Given this list of marker genes Braf, Id2, Cdh4, Cd40lg, Pbrm1 (NCBI Gene Id 76748), Fmr1, Tox, Ace, Dcstamp, Ptk2, Cul7, Vsir, Stk25, Mtor, Lmod3, Cdkl5, Nlrp3, Tiam2, Ctf2, Cdkl3, Il15, Smarcd1, Sgk1, Ascl1, Fbxo31, Nrp1, Islr2, Wls (NCBI Gene Id 99763), Ilk, Il6, Cftr, Sox13, Sart1, Sox4, Ccr1, Ctnnb1 (catenin beta 1, NCBI Gene Id 12387), Nkx6-1, Zfyve27, Dixdc1, Xrcc6, Disc1, Dhx36, H2-Ea, Igf1, Pax6, Sox11, Ell3, Pak3, Il10 (interleukin 10), Bhlhb9, Serpinf1, Mfn2, Wnt5a, Il2, Olig2, Smarca4, Rnd2, Itpkb, Il4, Atp11c, Ror2, Ntrk2, Slc9b2, Ist1, Ss18l1, Mir124a-1, Slc7a5, Aurka, Eif2b2, Ap3b1, Stk11, Evi2, Mmp14, Myb, Clec7a, Mir124a-2, Rtn4, Ntn1, Mpl, Lig4, Nr2e1, Fos, Kdm1a, Ptpra, Chodl, Anapc2, Trf, Cyp51, Actb, Cip2a, Gfap, Tgfb1, Amigo1, Mup20, Fgf2, Ccl19, Pou4f1, Smurf1 (SMAD specific E3 ubiquitin protein ligase 1), Rhoa, Grip2, Fxn, Rb1 (NCBI Gene Id 19645), Nrdc, Myod1, Cd83, Dbnl, Nrg1, Il7r, Cd1d1, Dbn1, Zbtb7b, Actl6b, Ufl1, Cx3cr1, Gas6, Proc, Synj1, Tnfrsf11a, Trem2, Rassf10 (NCBI Gene Id 78748), Stat5b, Actn3, Irf1, Smarcd3, Otp, Ccl9, Fbxw8, Pak1, Car2, Plxnb2, Ppp3ca, Nkx2-2os, Il20, Jade2, Ptn, Vnn1, Kalrn, Actr3, Carmil2, Cux2, Pcid2, Lrp8, Snap91, Bmp4, Sox2, Gimap3, Ptprd, Limk1, Rara, Itpka (NCBI Gene Id 228550), Srrt (serrate RNA effector molecule homolog (Arabidopsis)), Map3k13 (mitogen-activated protein kinase kinase kinase 13), Snw1 (SNW domain containing 1), Xrcc2, Gja1, Nckap1l, Ppargc1b, Aspa, Il3, Pparg, Il1rl2, Bcl11a, Dlk1 (NCBI Gene Id 13386), Plxnb3, Clcn2, Inpp5d (inositol polyphosphate-5-phosphatase D), Mdk, Hdac2, Mag, S1pr2, Dicer1, Tle6, Tnfsf4, Evi2b (ecotropic viral integration site 2b), Map2k2, Twf2, Sox10, Nkap, Neurl1a, L1cam, Bcl2, Zbtb46, Tespa1, Spen (NCBI Gene Id 56381), Hsp90aa1, Il2ra (NCBI Gene Id 16184), Ccr2, Cask, Wnt2, Acin1, Tescl, Hif1a (NCBI Gene Id 15251), Ninj1, Smarcd2, Plxnb1 (NCBI Gene Id 70220), Shh, Zfp36l1 (zinc finger protein 36, C3H type-like 1), Ephb2, Zmiz1, Bex1, Slc30a1, Gjc2, Tbc1d24, Cd4, Gdi1, Ptprc, Creb1, Rhoh, Lilrb4b, Prkci, Smarcc2, Hdac1 (NCBI Gene Id 630524), Map1b, Vegfa, Fzd3, Faim, Egr2, Zbtb1, Cdh5, Ddrgk1, Shank3, Hap1, Map2k1, Ankrd27, Golga4, Ager (NCBI Gene Id 11596), Trp73, Smarce1, Ccr7 (NCBI Gene Id 12775), Jun, Ikzf1, Reln, Nin, Clcf1, Metrn, Brd2 (bromodomain containing 2), Tmem64, Ngf, Klhl25, Pck1, Etv5, Dnm1l, Pou4f2, Il4ra, Kit, Gimap5, Wdr62, Plxnc1, Dscam, Actl6a, Rela, Lilrb4a, Pla2g3 (NCBI Gene Id 237625), Smad7, Tiam1, Zfp488, Star, Il17a, Socs1, Rufy3, Qki, Grip1, Spint1, Ccl3, Arid2, Dcx, Il12a, Stat5a (NCBI Gene Id 20850), Mecp2 (methyl CpG binding protein 2), Nap1l1, Pnp, Add1, Baiap2, Abcb1a, Ppp1cc, Tnfrsf12a, Myf5, Fxr1, Il18, Wnt3, Rnf112, Anxa1, Serpine2, Asxl2, Grm5, Prpf19 (pre-mRNA processing factor 19), Nkx6-2, Mapk8 (mitogen-activated protein kinase 8), Nedd9, Gfi1b, F11r, Vegfc, Gsk3b, Mir219a-2, Pias2, Ccr1l1, Marcks, Nptn, Foxg1, Tlr9, Lyn, Il5, Arid1a, Skint1, Malt1, Hes1, Sema7a (NCBI Gene Id 78407), Pik3r6, Xlr3b, Runx3, Cldn5, Brd4, Bin1, Hoxd11, Parp6, Zap70, Man2a1, Dmrta2, Prl2c2, Adcy10, Crabp2, Ndel1, Lta, Cyfip1, Wnt3a, Egr3, Tgfbr2, Foxo3, Nfkbid, Shb (src homology 2 domain-containing transforming protein B), Cbfb, Arrb2, Mir219a-1, Adipoq, Hdac6, Smarcc1, Bmp2, Il23a, Picalm, Ep300, Mfn1, Arhgap32, Akap5, Syk, Hcls1, Cd74, Trpc5, E2f1, Myf6, Gata3, Tspo, Nfkbiz, Hsf1, Eeig1, Lpar3 (NCBI Gene Id 65086), Prmt5, Brd7, Plag1, Eef2k (eukaryotic elongation factor-2 kinase), Smarcb1, Camk2b, Axl (AXL receptor tyrosine kinase), Lgals9, Numb, Adam8, Xbp1, Numbl, Ihh, Shtn1, Ptprz1, Ifng, Flt1, Nog, Myc, Egfr, Mme, Kdr, Caprin2, Sh3glb1, Fxr2, Ada, Sox12, Smo, Rgs14, Zfp335, Phf10, Cx3cl1, Foxp3, Xrcc4, Lif, Cd27, Nkx2-2, Klf10, Rptor, Cdon, Oprm1, Zfp609, Bnc1, Fzd4, Bmpr2, Epha4, Afdn, Tlr2, Tnfsf9, Apoe, Hmgb1, Il36b, Il4i1, Spi1, Mir326, Il1b, Aspm, Fadd, Prkdc, Caprin1, Gli3, Flt3l, Tnfrsf1b, Kitl, Robo1, Dag1, Trim32, Myo5b, Hax1, Bad, Atxn1, Gpr68, Fes, Csf1, Itgb1, Id4, Sema5a, Cysltr1, Csf1r, Ccl5, Cxcl12, Map6, Trak1, Nefl, Mir23a (microRNA 23a), Dll3, Lrp1, Macf1, Ambra1, Ctnnbip1, Xrcc5, Traf6, Tyrobp, Ntf3, H2-M3, Sirt2, Bag1, Adam7, Hlx, Bcl6, Tnfsf11, Rheb, Pde3a, Cxcr4, Socs5, Sox8, Tgm2, Myog, Ppp2r3c, Lck, Actr2, Pde5a, Rab21 (RAB21, member RAS oncogene family), Prkca, Itgam, Gh, Il33, Megf8, Pafah1b1, Mir124a-3, Srf, Golga2, Il15ra, Dusp10, Drd2, Il1rapl1, Stau2, Zeb2, Il7, Plxnd1, Trpv2, Dct, Il6st, Ocstamp, Rpl4, Shox2, Slitrk1 (SLIT and NTRK-like family, member 1), Eif4g2, Tenm4, Cyld, Kras, Rag1, Lef1, Il2rg, Smarca2, Sema4d, Tnf, Mapt, Kat5, Tesc, Ripk2, Sash3, Zfp365, Gnas, Trib1, Met, Ptprf, Ache, Ripk1, Enpp2, Runx1, Gsx2, Akap11, Rfx3 (NCBI Gene Id 320548), Vim, Ntrk3, Il12b, Gper1, Cux1, Cd46, Btn2a2, Myrf, Obsl1, H2-Aa, Notch2, Robo2, Bdnf, Hoxa11, Prkch, Adnp, Dlg4, Il34, Il21, Cd101, Skil, Ret, Tmprss12, Fn1, Mir223 (microRNA 223), Ap3d1, Itgb3, Notch1, Wnt10b, Rasgrp1, Khdc3, Lrp2, Efna5, Tnik, Opa1, Casp8, H2-DMa, Prkcz, here is a description of the gene set: Any process that increases the rate, frequency or extent of the progression of the cell over time, from its formation to the mature structure. Cell development does not include the steps involved in committing a cell to a specific fate. Mouse Gene Set: GOBP_POSITIVE_REGULATION_OF_CELL_DEVELOPMENT species: Mus musculus